Given this list of marker genes ANKRD13B, DNAJB5, PTGIR (NCBI Gene Id 5739), VCP, ZBTB39, ASXL1, PHC2, LGALS3, ALX4, MTURN, RARG, KCTD15, TAOK2, PRDM8, DCAF1, SOCS1, ENSA, PARP10, ZNF609, IGF2BP1, NBEA, MAP2K7, CREBRF, FURIN, CRIM1, SEMA6A, GABBR1, DAG1 (NCBI Gene Id 1605), SNX17, RIC8B, TAMALIN, LRCH4, EXOC7, CNTNAP4, NSD2 (nuclear receptor binding SET domain protein 2), SYT7 (NCBI Gene Id 9066), BAIAP2, ATP1B4, MYCL, ABHD17A, AIRIM, KMT5A, YPEL4, PLPP7 (NCBI Gene Id 84906), RAB5B, TBC1D10B, PABPN1, B4GALT2, NEUROD2, MBD6, KSR1, TSPOAP1, PHLPP1, RELL2, PCNX2, OSR2, CACNB1, GGT7, SLC25A1, ZNF652, FHIP2B, PPP2R5B, DLGAP4, VTI1A, NRP2, TCEANC2, MEIS1, EGR3, KHNYN, GNB2, AP2A1, LDLRAD2, GNAZ, XPO7, HOXA3, USP2, B4GALT5, ATOH8, SPRY4, RIMS4, POLR3H, ZNF513, FXR2, MINK1, TSPAN18, CLDN2 (claudin 2), CPLX2, ATXN2L, CPSF2, RHCG, FAM78B, RAF1, MIDEAS, FBXL19-AS1, NKIRAS2, MEIS2, here is a description of the gene set: species: Homo sapiens Human Gene Set: CCAGGGG_MIR331 Genes having at least one occurence of the motif CCAGGGG in their 3' untranslated region. The motif represents putative target (that is, seed match) of human mature miRNA hsa-miR-331 (v7.1 miRBase).